Given this list of marker genes EPB41L5, IQSEC1, MAPRE2, PIK3R1, ABL1, LIMS1, TSC1, S100A10, ROCK1, ITGB1BP1, TEK, NRP1, POLDIP2, SMAD3, MAP4K4, PPM1F, HRG, FERMT2, VEGFA, MYOC (myocilin), DUSP3, SFRP1, RAC1, ARF6, CFL1, SDC4, KDR, PTPRJ (NCBI Gene Id 5795), WNT4, COL16A1 (NCBI Gene Id 1307), THY1, here is a description of the gene set: Any process that activates or increases the frequency, rate or extent of cell-substrate junction organization. studied in species Homo sapiens Human Gene Set: GOBP_POSITIVE_REGULATION_OF_CELL_SUBSTRATE_JUNCTION_ORGANIZATION